Given this list of marker genes Gm10190, Gm33055, Gm49984, Gm6548, 1700106O07Rik, Gm18649, Galm, Gm9390, Gpx4-ps1, Slc8a1, Rpl31-ps25 (NCBI Gene Id 668832), Gm23125, Eif2ak2, Morn2, Hdac1-ps, Strn, Gemin6, Gm6552, Gm41625, Ttc39d, Prkd3, Vit, Gm6594, Sult6b1, Gpatch11, Cebpz, Srsf7, Heatr5b, Map4k3, Qpct, Rpsa-ps7, Rmdn2, Gm22386, Gm4599, Gm5230, Tmem178, Gm22215, Ndufaf7, Cyp1b1, Arhgef33, Cdc42ep3, Gm17315, Gm33373, Thumpd2, C230072F16Rik, Cebpzos, Gm9386, Cdkl4, Gm50045, Sos1, Gm19399, Atl2, Dhx57, Hnrnpll, here is a description of the gene set: Mouse Gene Set: chr17E3 studied in species Mus musculus